Given this list of marker genes INCENP, CDCA8, AURKC, AURKA, AURKB, BIRC5, here is a description of the gene set: A eukaryotically conserved protein complex that localizes to kinetochores in early mitosis, the spindle mid-zone in anaphase B and to the telophase midbody. It has been proposed that the passenger complex coordinates various events based on its location to different structures during the course of mitosis. Complex members include the BIR-domain-containing protein Survivin, Aurora kinase, INCENP and Borealin. species: Homo sapiens Human Gene Set: GOCC_CHROMOSOME_PASSENGER_COMPLEX